Given this list of marker genes Tjp2, Btn1a1, Tgfb3, Myh11, Ceacam1, Krt19, Mrc2, Tspan8, Dsp, Tacstd2, Galc, Adm, Prom2, Gab1 (growth factor receptor bound protein 2-associated protein 1), Phlda1, Gys2, Gadd45a, Lrp5, Cspg4, Cables1, Ogt, Cemip2, Tmprss2, Aldoc, Apoc2, Sgtb, Foxa1, Socs6, Ehf, Lima1, Tmem45b, Hal, Ptpn14, Cyp2d22, Pi16, Ednra, St14, Dbp, Shroom3, Tie1, Cdk1, Itfg1, Cdh5, Adissp, Bmp1, Fgg, Dnm1, Slc15a2, Id4, Wfdc2, Comt, Krt7 (NCBI Gene Id 28074), Cdh1, Slc2a5, Pgap2, Scd1, Basp1, Cdcp1, Atp6v0a1, Lgals3, Fn1, Atp6v1b1, Nhsl3, Tmem51, Fbxo32, Acsf2, Chi3l1, Runx1, Ccn1, Col9a1, Rnase2a (ribonuclease, RNase A family, 2A (liver, eosinophil-derived neurotoxin)), Rad51ap1, Fam241b, Hsd11b1, Slc12a2, Acly, Cdkn2b, Csn3 (NCBI Gene Id 12994), Epdr1, Plk2, Myb, Grhl1, Hacd4, Fgf13, Tmem109, Tlcd4, Egr2, Tmem79, Ank (progressive ankylosis), Irx2, Ptpn5, Rab27b, Lrrk1, Sc5d, Gsta3, Clca3a2, Atp8a1 (NCBI Gene Id 11980), Elf5, Gsn, Snorc, Slc39a8, Tfap2c, Mtch2, Slc25a24, Cnn1, Cd55, Tnc, Mkrn1, Lipg, P2rx5, C2cd2l, Gja1, Irf6, Sprr1a, Pdk1, Dnajc12, Nfe2l3, Dlat, Adgrd1, Esrp1, Cxcl15, Cited1, Ptn, Acaca, Mapk8ip1, Fads2, Gmpr, Gm2a, Siah2, Col8a1, Tmem268, Lalba, Sox9, Cldn10, Gata3, Tgif1, Krt14, Muc15, Cd248, Sox13, Ear1, Tnfrsf12a, Has2, Cops2, 2610528J11Rik, Rassf3, Scd3, Carhsp1, Serpina1b, Cux1, Mafb, Prpf19, Wwc1, Tead2, Ly6d, Inhbb, Mlph, Krt18, Hk1, Plet1, Col16a1, Mfge8, Ltf, Slc38a10, Srpx2, Kit, Hspa1b (heat shock protein 1B), Sfrp1, Gabrp, Ets2, Kcnb1, Elovl6, Epcam, Igha, Lratd1, Ano1, Fscn1, Mmp14, Unc119, Cyb5r3, Hspb8, Trps1, Spp1, Hdac11, Jchain, Mup1, Efemp1, Tfcp2l1, Csn1s1, Rassf2, Cldn3, Igfbp2, Slc25a35, Bltp3a, Bex3, Sdc1, Atp1a3, Irx3, Mtarc1, H2-Eb1, Prkce (protein kinase C, epsilon), Stc2, Lcn2, Bmyc, Aqp5, Scd2, Cxcl14, Fzd1, Clu, Fxyd3, Prkacb, Krt8, Pear1, Rnf149, Perp, Abcc3, Padi2, Gas1, Gabarapl1, here is a description of the gene set: species: Mus musculus Mouse Gene Set: MCBRYAN_PUBERTAL_BREAST_3_4WK_UP Expression microarray analysis identified over genes regulated during puberty in the mouse mammary gland. Most prominent were genes whose expression increased in parallel with pubertal development and remained high thereafter. Members of the Wnt, transforming growth factor-beta and oestrogen-signalling pathways were significantly overrepresented. Comparison to expression data from CITED1 knockout mice identified a subset of oestrogen-responsive genes displaying altered expression in the absence of CITED1. Included in this subset are stanniocalcin2 (Stc2) and amphiregulin (Areg). Chromatin immunoprecipitation revealed that ERalpha binds to oestrogen response elements in both the Stc2 and Areg genes in the mammary gland during puberty. Additionally, CITED1 and ERalpha localize to the same epithelial cells of the pubertal mammary gland, supporting a role for interaction of these two proteins during normal development. In a human breast cancer data set, expression of Stc2, Areg and CITED1 parallel that of ERalpha. Similar to ERalpha, CITED1 expression correlates with good outcome in breast cancer, implying that potential maintenance of the ERalpha-CITED1 co-regulated signalling pathway in breast tumours can indicate good prognosis. from publication McBryan J, Howlin J, Kenny PA, Shioda T, Martin F (PMID 17486082) Genes up-regulated during pubertal mammary gland development between weeks 3 and 4.